The following is a description of a gene set: Human Gene Set: HAY_BONE_MARROW_STROMAL from publication Hay SB, Ferchen K, Chetal K, Grimes HL, Salomonis N (PMID 30243574) species: Homo sapiens, and this is the list of marker genes: LOXL1 (NCBI Gene Id 4016), TRIM47, SATB2-AS1, CCBE1, BBOX1, NLGN4X, SEPTIN4, BGN, GPC4, MEDAG, ITGA1, LAMB2, BPIFB4, TWIST2, BNC2-AS1, SCARA3, EYA1, ADAMTS2, TRABD2B, SLCO1C1, PCOLCE, THSD7B, PMEPA1, PDGFRA, LINC02881, CYBRD1, NGFR, LINC02104, PCDHB7, VEGFC, ADIPOQ, SLC2A10, CXCL14, RGS3, PTPRM, AQP7, FABP4, ENSG00000254251, SYNPO2, ADAMTS9, TBX15, CCN1, IGFBP3, GPR153, C11orf87, PHLDA3, P3H2, LHFPL6, FILIP1, CPA1, PLA2R1, RUNX1T1, RAMP2 (NCBI Gene Id 10266), S1PR3, KIAA1755, PREX2, HEPH, SHC2, CNTN1, TMEM37, CFAP90, TNFRSF11B, ENSG00000253163, KIAA1217, MSI1, CORO6 (NCBI Gene Id 84940), VWA1, PPIC, SLPI, MAPK10, CAVIN1, HSPB2, NRXN3, C1S, ERRFI1, NFATC4, CD63, ZNF503, SIX1, TNS3, RFTN2, MT1A, NECTIN2, TJP1 (NCBI Gene Id 7082), FRMD4A, TEAD2, LAMC1, PITX2, IL7, CAV2, FMO3, ENPEP, ADAMDEC1, PDGFRL, ZFHX4, MARCKS, MMP14, CBLN2, SLC6A1, SDC3, VCAM1, KLF15, COL6A2, LTBP2, GAS6, MLF1, PCDHB10, TACR1, KRT27, OLFML3, TLL1, TSPAN8, CTSK, PTN, IGFBP2, CHRDL2, SERTAD4, RARRES2, DENND2B, CSRNP3, EBF3, NBL1, AKR1C2, C1orf122, GPR88, GLDN, CDH11, CDC42EP1, TENM2, COL6A1 (collagen type VI alpha 1 chain), RBFOX2, GAREM1, FOLR1, TF, FHL1, MT1E, MCC, TNFRSF12A, LINC01836, DMD, DPYSL3, ENAH, SLC22A3, CHST3, LRFN5, CP, LINC00967, C14orf180, SLC25A25, TMEM35A, HOXC8, CYP1B1, S100A13, PDZRN4, MMRN2, EMP1, RBP1, KCNE4, APOB, LIMCH1 (LIM and calponin homology domains 1), PGM5P3-AS1, HCRTR2, MTSS2, PRTG, TMEM59, FAM114A1, GPX3, CD276, IL1R1, GLT8D2, ABCC8, COL5A1, EYA4, SERPINH1, AGTR1, ARHGEF28 (NCBI Gene Id 64283), HMGCLL1, ARSJ, MYO10, MT2A, NCAM2, PLEKHH2, EGFLAM, TIMP3, VASN, NUPR1, TNS2, TMEM50A, BMP5, LRRC4C, COL6A3 (NCBI Gene Id 1293), ADAMTSL3, PTPN13, HOXC6, PCDHB5, PALMD, PTH1R, MSX1, FRZB, ANK2, TRIM55, FOXD1, GFRA1, C1QTNF1, HOXD8, LINC02609, C7, IRS1, SAMD11, FLRT2, RHBDF1, PRRX1, SLC7A2, BPIFB1, TDO2, TMEM98, TNFAIP6, NRP2, MYO1B, MDK, S100A16, SEMA6D, OLFML1, LY6K, CXCL2, BOC, FN1, LEPROT, FST, SLIT2, MYO6 (myosin VI), MFSD2A, FKBP9, BPIFA2, TINAGL1, LGALS3BP, OLFM4, PLS3, KCNIP3, HOXC10, EPS8, ENSG00000272473, SCUBE1, TMEM108, GPRC5B, COL16A1, RBMS3-AS3, HSD11B2, ACSM5, HOXC9, PTGIS, CRYAB, MXRA5, SERPING1, DAAM2, CCDC8, SSPN, LRATD1, PNLIPRP3, TMEM179, JUN, LINC01638, CHSY3, ARHGEF10, DMRTA1, GMDS, GALNT17, PXDC1, MRGPRF, SPATA18, SIX6, AMOTL2, NNMT, TNKS1BP1, ITGBL1, SFRP5, PPFIA2, DNALI1, FAT3, LUM (lumican), INSIG2, IGDCC4, ANGPT4, COL5A3, PLPP3, FMO2, GULP1, MMP19, PLSCR4, PLPP1 (phospholipid phosphatase 1), C1R, ATF3, FZD8, NPNT (NCBI Gene Id 255743), TM4SF1, ERRFI1-DT, LPIN3, DDR2, COL5A2, NAV3, FGFR3, CDO1, EMP2, WFDC2, COL3A1, NCKAP5, FBLN1, TBX18, ADM, PCSK6, EMX2, C11orf96, TM6SF2, BCAR1, EDNRB, ZNF488, IL34, RHOJ (ras homolog family member J), DPT, SMARCA1, CNTFR, IL1RAPL1, NRXN2, FRMD6, WWTR1, FKBP10, RARRES1, MATN3, TMEM132C, WDR86, TMEM45A, ACKR3, THBS2, CCN6, SPRY4, NPB, SNCAIP, MTARC2, DCN, PLEKHA5, RGS22, WNT4, RCN1, PLA2G5, PRELP, COL4A1, PPARG, SOX9, LGI4, MALL, GGT5 (NCBI Gene Id 2687), DLX5, PRRX2, ABCA9, GPX8, FLRT3, KITLG, PTX3, CYP2A7, EDIL3, CPN2, DLC1, COL21A1, CDH5 (cadherin 5), IRX5, ESM1, FGF7, NFASC, EDNRA, FZD5, CCN5, UNC5C, ADH1B, AGT, RTN4RL1, HP, SORBS2, GPRC5A (NCBI Gene Id 9052), LMCD1 (LIM and cysteine rich domains 1), CLIC4, ENSG00000227496, TPST1, MMP2, CLMP, ENOX1, ITIH5, MROCKI, PODN, GUCY1A2, RAI14, GADD45A, SYDE1, COL1A1, COL28A1, NALCN, CCL8 (NCBI Gene Id 96488), LOX, PCDHGA2, SNHG18, MSC-AS1, GLI3, PLEKHA4, RETREG1 (reticulophagy regulator 1), CACNA2D1, TMEM200B, TNC, FARP1, LINC01348, CNN3, MIR497HG, CRIM1, CCL13, COL14A1, FZD1, COL1A2, EGR1, CDC42EP4, DLX6, NOTCH3, C5orf15, FGF1, DYNC1I1, RNF180, GHR, ALX4, RUNX1, GJA1, PYGO1, PDE1A, TRARG1, RORB, APLNR, FERMT2, PCDHB6, ADH1C, OLFML2A, SERTAD4-AS1, FZD4, NID1, CHRNA3, CAV1, LINC00922, FGFR1, LINGO1, RSPO3, TENM3-AS1, ADIRF, LINC00640, CHRDL1, GPM6B, RBMS3, HOXD3, THSD4, RGS16, SLC39A14, NRXN1, TMEM233, PANX1, FKBP7 (NCBI Gene Id 51661), CXCL12, CHRD, IGFBP5, NTRK2 (NCBI Gene Id 4915), ZFP36, KIRREL1, FNDC4, FBXL7, ABCA10 (NCBI Gene Id 55400), LMNA, DRD1, NDN, PODNL1, ECRG4 (NCBI Gene Id 84417), FOXC2, CDH15, INHBB, CIDEA, FAP, PLAC9 (placenta associated 9), FBXO17, CHL1, EPAS1, TUSC3, GSN, CDC42EP5, SGCE, CCL2, NR2F1 (nuclear receptor subfamily 2 group F member 1), SOCS3-DT, CSF1, OSMR, MAGI1, STEAP2, FNDC1, EPB41L4B, LINC02381, TMEM150C, ANTXR1, SRPX2, CLDN11, NHERF2, ABCA8, PTPN21, NECAB1, MGP, ARHGAP20, THY1, CFD, NFIB, SH3PXD2B, HOTAIR, BMP4, FAM13C, SNCG, LRIG3, PPP1R3C, KIF7, OTOGL, FIBIN, KCNH1, TFPI, SMOC1, IRX2-DT, ARHGEF17, CACHD1, NR2F2-AS1, GASK1A, CH25H, TCF7L1, ALPL, EFEMP2, ARMCX2, IGF2, TEAD3, SMOC2, TRAM1L1, MRGPRF-AS1, TSPAN4, SOCS3, ADGRL2, COL12A1, DOK5, EGFR, CD81, DENND2B-AS1, PTGDS (NCBI Gene Id 5730), NRP1, MEIS2, PAPPA, FAT1, IL6, VGLL3, EMILIN1, RAPH1, CYP4X1, DENND2A, OSR2 (odd-skipped related transciption factor 2), OLFML2B, LAMA4, MYL3, MAPK4, FAM20A, HOXD11, RBMS1, RAPGEF4, TACC2, ADAMTS1, MYH14, SIX2, CLCA2, ISLR, MID1, MDFI, JAG1, NR2F1-AS1, TEAD1, IGFBP4, PTGFR, ASS1, ABI3BP, SLC1A3, CPXM2, RSPO1, KRTAP13-4, HSD11B1, WASF3 (NCBI Gene Id 10810), SGCB, NXPH3, ZCCHC24 (zinc finger CCHC-type containing 24), CYP11A1, HTRA1, LINC01140, CAVIN3, CRABP1, MOCS1, MXRA8, ITGB5 (integrin subunit beta 5), LRRC10B, OSMR-DT, FOXC1, COL7A1, TNFRSF1A, PLIN4, SVEP1, EFS, DIO3OS, CRISPLD1, RGL1, LIMA1, LBP, CFH, NLGN1, ANGPTL4 (angiopoietin like 4), NID2, COL11A1, EFNB1, ASPA, APOD, TESHL, PCDHB16, SERTAD1, RCN3, TMEM100, LINC01139 (long intergenic non-protein coding RNA 1139), PCDHB14, SLIT3 (slit guidance ligand 3), FSTL1, ROR2, GAS1, MAP1LC3A, RASD1 (ras related dexamethasone induced 1), ANGPT1, TMEM119, ENPP2, SELENOP, EPHA3, GLIS2, SELENOM, PALLD, BMP2 (NCBI Gene Id 650), FMOD, LARP6, UNC5B, GNG12, MT1M, CCDC80, MEGF10, DAPK2, RND3, SFRP1, PLIN1, SOD3, LEPR, RASL11A, SRPX, TNS2-AS1, LIFR, ITGB6, FBN1, TAGLN, PCDHB12, HAS2, NPY1R, KRT222, SULF1, STEAP1, LINC01436, NR2F2, GLI2, ID3, ZIC1, CRH, DCLK1, HSPA12A, COX7A1, FOXO6-AS1, SPRY1, PCGF2, PTPRG, CFI, RGL3, SNX7, TWIST1 (NCBI Gene Id 7967), DZIP1, ID4, POU6F2, CCN2, PDGFRB, TMEM54, EFNA1, NLGN4Y, YAP1, SPARCL1, PRICKLE2, APOE, MARK1, TPBG, IRX3, PDE1C, COL4A2, SNAI2 (snail family transcriptional repressor 2), CYP39A1, TMEM47, TIMP4, EPHX1, DEPP1, CALD1, EFEMP1, BMPER, CXCL3, RND1, EFHD1, FZD7, SMAD9, TMEM64, LAPTM4A, NCKAP1 (NCBI Gene Id 9864), SEMA3G, PARVA, NAV2, ADAMTS9-AS2, ITGAV, HOXD-AS2, LINC01117, HRCT1, MRC2, SLC7A10, SSTR2, IRX2, PDLIM4, LINC01426, FOSB, TNFRSF19, GADD45B, TSKU, IL6ST, PCDH18, ARHGAP28, LDLR, RRAD, PFN2 (profilin 2), ALDH1A3, ANGPTL2, LINC01686, FRMD6-AS2, ECM2, ARHGEF25, TRIP10, PABPC5, ACSS3, GEM, PLEKHS1, HOXD4, NMB, ZNF423, CTSO, IGFBP7, ABCA6, PLN, HSPG2, ZNF676, LPL, IGFBP6, PCDHB15, SATB2, BICC1, HES1, KCNT2, PGF, TRHDE, TENM4